Given this list of marker genes Vps35, Zdhhc1, Hdac6, Isg15, Jmjd6, Trim65 (NCBI Gene Id 338364), Abca3, here is a description of the gene set: studied in species Mus musculus Any process that modulates the frequency, rate or extent of protein oligomerization. Mouse Gene Set: GOBP_REGULATION_OF_PROTEIN_OLIGOMERIZATION